Given this list of marker genes Tfam, here is a description of the gene set: part of: Transcription from mitochondrial promoters This event has been computationally inferred from an event that has been demonstrated in another species.<p>The inference is based on the homology mapping from PANTHER. Briefly, reactions for which all involved PhysicalEntities (in input, output and catalyst) have a mapped orthologue/paralogue (for complexes at least 75% of components must have a mapping) are inferred to the other species. studied in species Mus musculus Reactome Pathway: Mitochondrial transcription initiation electronically inferred by orthology from the curated human pathway